Given this list of marker genes AQP4, ADGRG1, MT3, MLC1, SLC17A8, ADCY10, ATP1B2, HEPACAM, CLCN2, EIF2S1, SLC2A13, GFAP, here is a description of the gene set: Terminal process of astrocyte abutting non-neuronal surfaces in the brain. studied in species Homo sapiens Human Gene Set: GOCC_ASTROCYTE_END_FOOT